The following is a description of a gene set: Abnormality of the epiphyses of the distal phalanx of finger Any anomaly of distal epiphysis of phalanx of finger. species: Homo sapiens Human Gene Set: HP_ABNORMALITY_OF_THE_EPIPHYSES_OF_THE_DISTAL_PHALANX_OF_FINGER, and this is the list of marker genes: SRCAP, MRPS28, TRPS1, ARSL, GDF5, BMPR1B